The following is a description of a gene set: studied in species Mus musculus from publication Chen Y, Wang X (PMID 31504780) Genes predicted to be targets of miRBase v22 microRNA mmu_miR_3105_3p in miRDB v6.0 with MirTarget v4 prediction scores > 80 (high confidence targets). Mouse Gene Set: MIR_3105_3P, and this is the list of marker genes: Cdc42ep3, Btbd3, Asb7, Rps6ka4, Fhip2a, Arhgap15, Scn8a, Ngly1, Adam10, Hunk, Glt28d2, Il36rn, Cpsf6, Dcdc2a, Usp48, Slc24a5, Mis18bp1, Fam210a, Fut9, Eif4g2, Chchd6, Pkn2, Atp11c, Btbd1, Ddx3x, Rnf169, Fbxo32, Gabpa, Ptger2, Onecut2, Rai2, Stk38, Sprr3, Cyp1b1, Arl8b, Cnot4, Alg13, Ywhah, Ubr3, Phf21a, Slc4a4, Homer1, Phospho1, Slc4a10, Reps1, Cdkn2c, Golph3l, Arhgap31, Nkiras1, Megf10, Klf4 (NCBI Gene Id 269540), Nek4, Unc5d, Nsmaf, Cacul1, Pclaf, Gnl3l, Map3k13, Kif14, Thg1l, Stag2, Zfand1, Foxo3, Fmo5, Nat8f2, Sh3bgrl, Eps8, Oas2 (2'-5' oligoadenylate synthetase 2), Frmd5, Csnk2a2, Npr3, Pttg1ip, Slc39a12, Mcm6